Given this list of marker genes HRAS, MAPK14, SHC1, MAPK12, SHC2, MAPK13 (mitogen-activated protein kinase 13), SOS1, RALA, NTRK1 (NCBI Gene Id 7825), RALGDS, SRC, SHC3 (SHC adaptor protein 3), GRB2, MAPKAPK2, KRAS, NGF, RALB, MAPK11, NRAS, MAPKAPK3, here is a description of the gene set: Signalling to RAS Human Gene Set: REACTOME_SIGNALLING_TO_RAS species: Homo sapiens